Given this list of marker genes IGHG1, FCGR3A, FCGR1BP, FCGR2C, FCGR2A, C3, IL20RB, HLA-E, CCR7, IGHE, FCGR2B (Fc gamma receptor IIb), ZP3, FCER1G, FCGR1A, FCER1A, GATA3, SPN, FCGR3B, FUT7, BTK, EXT1, here is a description of the gene set: studied in species Homo sapiens An inflammatory response to an exogenous environmental antigen or an endogenous antigen initiated by the adaptive immune system. Human Gene Set: GOBP_HYPERSENSITIVITY